The following is a description of a gene set: Human Gene Set: HP_APLASIA_HYPOPLASIA_OF_THE_EPIGLOTTIS studied in species Homo sapiens This term applies if the Epiglottis is absent or hypoplastic. Aplasia/Hypoplasia of the Epiglottis, and this is the list of marker genes: FGF10, SETBP1, FGFR3, C2CD3, FGFR2, NEK1, PRRX1, GLI3, SF3B4, CILK1, EIF4A3, FREM2, DYNC2LI1